Given this list of marker genes PAX8, WNT7B, PKD1, DACT2, UMOD, AQP2, DLG5, PTCH1, AKR1B1, WNT9B, TFAP2B, PAX2, NOTCH1, SHH, CALB1, here is a description of the gene set: Human Gene Set: GOBP_COLLECTING_DUCT_DEVELOPMENT studied in species Homo sapiens The process whose specific outcome is the progression of a collecting duct over time, from its formation to the mature structure. The collecting duct responds to vasopressin and aldosterone to regulate water, electrolyte and acid-base balance. It is the final common path through which urine flows before entering the ureter and then emptying into the bladder.